Given this list of marker genes Psmc4, Psma5, Pttg1, Adrm1, Psmd7, Ccna1, Cdc16, Ube2e1, Anapc1, Cdc23, Psmd11, Psma7, Mad2l1, Anapc15, Anapc10, Psmd14, Anapc5 (NCBI Gene Id 67965), Psma6, Psmb3, Bub3, Psmb6, Ubb, Psmd3, Psmc2, Psma2, Psmc3 (NCBI Gene Id 19182), Psma3, Ube2d1, Psmb2, Anapc16, Psmd2, Bub1b, Uba52rt, Psmb5, Psma1 (proteasome subunit alpha 1), Anapc7, Anapc2, Cdc27, Cdc26, Psmd6, Nek2, Psmd1, Psmc5, Plk1, Ccna2, Cdk1, Psmb1, Psmb7, Ccnb1, Psmd8, Ube2c (NCBI Gene Id 68612), Uba52, Psmd13, Ubc, Psmd12, Psmc6, Ube2s, Rps27a, Psmc1, Psma4, Psmb4, Cdc20, Anapc11, Anapc4, here is a description of the gene set: Activation of APC/C and APC/C:Cdc20 mediated degradation of mitotic proteins studied in species Mus musculus Mouse Gene Set: REACTOME_ACTIVATION_OF_APC_C_AND_APC_C_CDC20_MEDIATED_DEGRADATION_OF_MITOTIC_PROTEINS